The following is a description of a gene set: This event has been computationally inferred from an event that has been demonstrated in another species.<p>The inference is based on the homology mapping from PANTHER. Briefly, reactions for which all involved PhysicalEntities (in input, output and catalyst) have a mapped orthologue/paralogue (for complexes at least 75% of components must have a mapping) are inferred to the other species. part of: Hedgehog 'on' state electronically inferred by orthology from the curated human pathway species: Mus musculus Reactome Pathway: Ligand-receptor interactions, and this is the list of marker genes: Ihh, Shh, Cdon, Gas1